Given this list of marker genes BRD4 (NCBI Gene Id 90616), MAD2L1BP, SKA1, MAD1L1, PPP1R10, SKA3, PRAP1, CHEK2, here is a description of the gene set: studied in species Homo sapiens Any process that stops, prevents or reduces the frequency, rate or extent of cell cycle checkpoint. Human Gene Set: GOBP_NEGATIVE_REGULATION_OF_CELL_CYCLE_CHECKPOINT